Given this list of marker genes Ovol2 (NCBI Gene Id 69059), Il17a, Zeb1, Zfp36, Fam3c, Ppard, Fgf7, Kdf1, Bcl11b, Cdh3, Fgf10, Med1, Kif3a, Ptprk, Stxbp4, Srsf6, Irf6, Ift74, Cask, Fgfr2, Wnt16, Ift172, Twist2, Zfp36l1, Klf9, Reg3g, Slurp2, Prkd1, Ift122, Sdr16c5, Ereg, Ctsl, Ift88 (intraflagellar transport 88), Cdh13, Snai2 (snail family zinc finger 2), Fermt1, Ovol1, Klk8, Cdkn1a, Trp63, Lrg1, Gpr15lg, Nfkbiz, Mdk, Fst, Tgm1 (NCBI Gene Id 69510), Ptch1, Crnn, Ift52, Krt2, Notch2 (notch 2), Ift57, Extl3, Vdr, Ift80, Cd109, Efnb2, Cdkn2a, Slurp1, Has2, Sfn, Eppk1, Nfatc1, Intu, Yap1, Reg3a, here is a description of the gene set: Mouse Gene Set: GOBP_KERATINOCYTE_PROLIFERATION studied in species Mus musculus The multiplication or reproduction of keratinocytes, resulting in the expansion of a cell population. Keratinocytes are epidermal cells which synthesize keratin and undergo a characteristic change as they move upward from the basal layers of the epidermis to the cornified (horny) layer of the skin.